The following is a description of a gene set: The development, homeostasis and function of B lymphocytes involve multiple rounds of B cell receptor (BCR)-controlled proliferation and prolonged maintenance. We analyzed the role of transcription factor Zfx, a recently identified regulator of stem cell maintenance, in B cell development and homeostasis. Conditional Zfx deletion in the bone marrow blocked B cell development at the pre-BCR selection checkpoint. Zfx deficiency in peripheral B cells caused impaired generation of the B-1 cell lineage, accelerated B cell turnover, depletion of mature recirculating cells, and delayed T-dependent antibody responses. Zfx-deficient B cells showed normal proximal BCR signaling, but impaired BCR-induced proliferation and survival. This was accompanied by aberrantly enhanced and prolonged integrated stress response, and delayed induction of Cyclin D2 and Bcl-xL proteins. Thus, Zfx restrains the stress response and couples antigen receptor signaling to B cell expansion and maintenance during development and peripheral homeostasis. species: Homo sapiens Human Gene Set: GSE13547_CTRL_VS_ANTI_IGM_STIM_BCELL_2H_UP from publication Arenzana TL, Smith-Raska MR, Reizis B (PMID 19329779) Genes up-regulated in B lymphocytes: control versus stimulated by anti-IgM for 2h., and this is the list of marker genes: LAG3, TRAFD1, DZIP3, CYTH3, PRC1, TGFB1, SGO2, KIF22, CLIC4, EZH2, BARD1, KIF14, PDCD1, MCM3, TIGIT, MTA2, VCP, ADGRG1, CLSPN, ETFB, AIM2, FBXO5, NEIL3, EIF3C, ATAD5, SLC23A2, KIF2C, ANK3, EGR2 (early growth response 2), CCNE1, CPT1A, CBX5, CELA1, TEC, HAVCR2, RRM2, INPP4B, KPNA2, ACSL5, ZBP1, RRM1, SEMA4D, MYO1G, TPX2, KIF4A, BRCA2, HNRNPUL1, FIGNL1, CASP4, VAMP8, MCM7, CD7, KIF15, FKBP5, DHX58 (DExH-box helicase 58), RAD51, XDH, STMN1, TNFRSF17, EIF2AK2, NCAPG2, PTPN13, LY75, RPA1, IFIT3, MX1, ASPM, STAT1, SF3A1, TCEAL9, APOBEC2, CDCA3, CENPA, IFIT1, PLK1 (polo like kinase 1), ROM1, CCNB2, BRIP1, CCDC34, TJP2 (tight junction protein 2), RBBP8 (RB binding protein 8, endonuclease), SPC25, SUOX, SRGAP3, DDX60, LCLAT1, CCL3, NEB (NCBI Gene Id 4755), PRIM1, POLE, CDC45 (NCBI Gene Id 8319), CDCA8, ADAM19, MIS18BP1, PSAT1, NSD2, PLXDC2, CDC14A, CENPH, INCENP, HERC5, ECT2, PRR11, PSMD14, WDHD1, NCAPD2, CD38, CDK6, CORO2A, CCNA2, AIDA, ESCO2, EOMES (NCBI Gene Id 8320), YEATS4, GCA, MKI67, CD200R1L, LIG1, PTGER2, CENPF, KIF11, CXCL10, GEN1, CKS1B, HOOK1, CENPE, USP18, KDM4A (NCBI Gene Id 9682), H2AZ1, TTK, CHEK1, TRIM25, HMMR, MCM6, ISG20, GLCCI1, NUF2, NCF1, BRCA1, TIPIN, TOX, CD86, IKZF2, MAD2L1, HELLS, TNFRSF18, FGL2, CKAP2, CENPS, AURKB, OCIAD2, GZMK, ARSB, RIPK3, PRR5L, NIBAN1, NCAPG, SEPTIN4, BUB1, FRMD4B, CDC25C, RNF213, TRIM5, H2AC4, RAD51AP1, CDKN3, CDK1, GGTA1, EHD4, TOP2A, H2AX, IFIH1, HNRNPLL, EPHX1 (NCBI Gene Id 2052), RSAD2, CSRP1, PPIP5K2, PLOD2, CALU, SGO1, MYO5A, CTLA4